The following is a description of a gene set: Human Gene Set: GSE12198_CTRL_VS_HIGH_IL2_STIM_NK_CELL_DN Genes down-regulated in NK cells: primary versus stimulated by high dose of IL2. Transcriptional profiling of NKAES-derived NK cells after 7 days of culture compared to primary human NK cells and NK cells stimulated by low or high dose IL2 after 7 days of culture. species: Homo sapiens from publication Fujisaki H, Kakuda H, Shimasaki N, Imai C, Ma J, Lockey T, Eldridge P, Leung WH, Campana D (PMID 19383914), and this is the list of marker genes: IFT57, F3, NFATC4, PEX19, IGFBP7, IKZF4, OSBPL11, RABGGTB, ODC1, FBXW12, CNNM4, DHX38, NTMT1, C1S, DCAF13, DEGS1, STX19, SHMT1, IGSF9, MOGS, PRKG1, GALNT1, RGS16, TP53INP2 (NCBI Gene Id 58476), NETO1 (neuropilin and tolloid like 1), DKK1, MRPL27, NOTCH2, ATOSB, FMNL3, BCL2L2, POPDC2, TMEM184B, ASS1, CPXM1, FGD6, SIRT2, VCF1, INO80C, MMP20, NOVA1, PDLIM2, LYZL1, UBL7 (ubiquitin like 7), NCF4, CDV3, DOCK2, DHX30, FLNB, TRAF2, MLLT3, MPHOSPH10, PLEKHJ1, SLC25A17, GNG11, PLEKHO1, EHD1, NMT2, GTF3A, ZNF277, PGPEP1, KRTAP19-3, PDE6D, ACLY, DRG1, IGFBPL1, AZIN1, CSNK1E, PRCP, MRPS16, MGAT5, SPA17, EDN2, WNT9A, SRM, CCNE1, SLC18A3, RNASE4, TLCD1, GPR37L1, YAF2 (NCBI Gene Id 10138), SPATA6, KANSL2, MYH9, MRPL57, TPST2, SNX3, U2AF1, PISD, NFKBIA, EFHD2, MAK16, DESI1, SNCG, UBE2M, SUN1, EVI2A, SUCLA2, FKBP4, DNMBP, TRIP10, IL16, PRKD2, IGSF6, RHOG, TRIM7, ELOA, SETD3, IFNGR2, C1QTNF12, IER2, CAPG, LDB1, TK1, ZBTB32, PTGDR, ANGPT2, TNFRSF13B, USP36, ADIPOQ, RANBP3, RARS1, GFRA1, DUS1L, KIN, HNRNPAB, HNRNPC, SQSTM1, NGEF, STARD10, ZCCHC9, CXCL10, GLI1, ABHD17C (abhydrolase domain containing 17C, depalmitoylase), PDLIM1, EGR2, GPR83, CHMP3, DENR, MLX, SERHL2 (serine hydrolase like 2), CCND2, AGFG2, NELFCD, FGD2, ROCK2, CCNB1IP1, KCTD10, DTX2, INTS8, PSMG4, CRTAC1, CALHM2, SFRP2 (NCBI Gene Id 6423), QNG1, HESX1, HDAC7, TSPAN17, PMEPA1, MOB1A, BMP8B, ZBTB17, CISH, VWA7, GMPPB, GABRG2, PYCARD, NUP88, PTPN6, UTP25, RBMX, FAM76A (family with sequence similarity 76 member A), CASKIN2, MAPK10, ORAI1, PARP3, HKDC1, PRKAG1, ARHGEF2, HPGDS (NCBI Gene Id 27306), MRPS6, PIGP (NCBI Gene Id 53821), RAB34, CCDC86, SLC46A1, DLST, SETDB1, TIMP2, PLK2, NFKBIE, TM9SF4, NACC1, MAPK14, RDH16, LTA, B4GALT1, MRPL15, FGF6, ADH5, UBE2J2